The following is a description of a gene set: from publication Chen Y, Wang X (PMID 31504780) Genes predicted to be targets of miRBase v22 microRNA hsa-miR-1-3p in miRDB v6.0 with MirTarget v4 prediction scores > 80 (high confidence targets). species: Homo sapiens Human Gene Set: MIR1_3P, and this is the list of marker genes: MAP4K2, SERP1, CEBPZ, THAP12, PAX3, SLC35G1, PTPN14, ACTB, SLC10A7, PRKACB, ARK2C, ATP6V1A, RABGAP1L, SP2, CD2AP, API5, GPR6, MCTP1, AZIN1, FNDC3A, WWC1, ANKRD29, ARHGAP20, MON2, PIK3C2A, HMBOX1, KCNMB2, ANXA2, CDK14, GPR137C, EBPL, RFLNB, PHIP, SLC25A36, PALS1, PDK3, SLC37A3, PHAX (NCBI Gene Id 84137), FLI1, NCOA1, UST, KTN1, SFRP1, HSP90B1, ZNF326, KCNJ2, SKIC8, PHF6, MYLK, CAAP1, MIPOL1, XPO6, KANK4, BCL11A, IMPACT, CCSAP, FAM91A1, SATB1, MAP4K3, SNX2, HP1BP3, MCHR1, LRCH1, GIPC2, ZEB2 (zinc finger E-box binding homeobox 2), MPP7, TPPP, SYT1, JOSD1, GCLC, STMN2, ARF3, PAX7, PLXNA4, TMEM178A, SOWAHC, FBXW7, ZFP36L1 (ZFP36 ring finger protein like 1, NCBI Gene Id 677), EML3, CLTC, ARCN1 (NCBI Gene Id 372), EDN1, ZFP36L2, TNKS2, GIT1, MEX3C, PIRT, DRD1, NDRG3 (NDRG family member 3), NRP1, PTPRG, SOX9, PLPPR4, PEAK1, GLCCI1, TMEM135 (NCBI Gene Id 65084), PRDM10, WBP1L, S100A7A (NCBI Gene Id 338324), NFATC3, GJA1, CAVIN2, JARID2, HIGD1A (HIG1 hypoxia inducible domain family member 1A), CPED1, MXD1, ETS1, CITED2, MMD, SRSF9, FRS2, CCDC146, STK39, PDCD10, CLCN3, ASH2L (ASH2 like, histone lysine methyltransferase complex subunit), PREX1, CREM, GPD2, TRAPPC3 (trafficking protein particle complex subunit 3), CREB5, ADAM12, NFAT5, CCL2 (C-C motif chemokine ligand 2, NCBI Gene Id 6347), SEC63, SLC39A10, AP1S1, CWC15, NXT2, ADAR, SLC25A53, TOX3, ARF4, TBC1D15, CHSY1, FAM72C, SAMD8, AJUBA, TPM4, EEIG1, PDE7A, MMD2, KAT6A, MBLAC2, LRRC8A, RARB, SLC35B3, CDKL5, SULF1, HIPK3, ZNF24, IGF1, NEXMIF, BCL7A, HACD3 (3-hydroxyacyl-CoA dehydratase 3), NINJ1, ADPGK, FAM72D, LAMP2, SCAF11, DACH1, ZNF280D (NCBI Gene Id 54816), MECOM, SLC8A2, ASRGL1, FUBP1, TWF1, SLC29A3, BACH2, GRK6, MATR3, INMT, NAB1, TAF1B, LRATD1, RNF138, SLC39A9, C2orf69, ZNF250, TMCC1, ASXL3, INSM1, BDNF, KIF2A, WDR1, SPRED1, FNDC3B, SLC6A11, CLOCK, EIF1AX, YWHAZ, PABPC1L2B, THRB, E2F5, RIT2, TBX3, MMRN1, ARPC3, CAPRIN1, ANP32E, EIF4E, METTL21A, TRIM2, ANXA4, BSCL2, MEA1, CREBL2, HSPD1, GPR158, PDIK1L, UTRN, SLC8A1, HELZ2, NETO2, THBS1, CORO1C, RAD54B, ZMAT3, ZBTB4, TFE3, MAL2, FAM72A, SRI, SEC23B, TNS3, RIMS4, RTN4IP1, ADGRA3 (NCBI Gene Id 166647), BTAF1, PRKCE, TTC7B, TMSB4X, YWHAQ, POGK, SEMA6D, FBXO33, ACER2, NET1 (neuroepithelial cell transforming 1), PPP4R2, RIMOC1, SEC22B, UBE2H, ATF2, TAGLN2, FAM72B, RFWD3, TMEM243, NUP50, SLC25A25, TIMP3, HACE1, KMT2E, TBX18, MFSD14A, ZNF547, SMIM14, PPIB, CCDC170, RBM27, SNAI2, HYCC1, UNC119B, RICTOR, RNF38 (ring finger protein 38), ZNF281, MRO, SMARCC1, SEC61A1, DDX5, DCP2, SLC25A30, DGKH, PDCD4, FOSB, STC2, CBL, MAX, HS3ST3B1, GNPDA2, FBXL14 (NCBI Gene Id 144699), DDX55, PFDN1, COL19A1, CCDC32, SRGAP2, HMGN1, PICALM, FOXP1, WDR48, GOLPH3, VAMP4, ZNF800, AP1B1, KCNIP3, UHMK1, PCDHB13, PCARE, NEDD9, CNN3, IP6K2, LIPI, NCL, CAP1, GCH1, NBEA, INTS6, MEOX2, FAM168A, GPR85 (G protein-coupled receptor 85), G6PD, NALF1, MGAT4A, BHLHE22, SRSF1, OSBPL7, WIPF2, NT5C1B-RDH14, AKAP11, SAMSN1, SS18, SH3TC2, RNF145, MINDY2, AP1G1, SUSD1, TRA2B, TNPO2, MSANTD2, FAIM, CTTNBP2NL, DLG1, PTPN1, CPEB1, LASP1, PPP4R3B, SLC38A3, KCTD10, KAT6B, MET, KLF4, NFATC2, UBE4A, TBCK, EPHB1, KMT5B, BPNT1 (NCBI Gene Id 10380), SMARCB1, PBX1, FUT3, SLC25A22, WNK3, ELF1, ZBTB6, RGS7, SLC7A2, NOL4L, IFT52, STARD7, HNRNPU, TSPAN4, HIVEP3, GLCE, ZBTB41, RAB5A, MAB21L1, FN1, MTX1, CERS2, ATG13, STAG2, SLC44A1, MYOCD, USP33, SPRN